The following is a description of a gene set: Genes up-regulated in the HSC supportive stromal cell lines. Human Gene Set: DURAND_STROMA_S_UP studied in species Mus musculus Stromal cell lines represent an exceptional tool to study the role on the microenvironment on hematopoietic stem cell (HSC) activity. We have compared the expression profile of HSC supportive vs non-supportive stromal lines generated from different hematopoietic tissues in the mouse, i.e the aorta-gonad-mesonephros (AGM) region, the fetal liver and the adult bone marrow, sequentially activated during development. In this study, six stromal lines were used with one HSC supportive and one non-supportive for each tissue (triplicate samples for each stromal line). We used Mouse Gene 1.0 ST microrrays in combination with GSEA and statistical analysis to identify lists of genes that segregate HSC supportive from non-supportive stromal lines., and this is the list of marker genes: PLXNA2, IL13RA1, TSPAN7, UBE2L6, PDK4, LRIG3, SLC37A2, PDLIM4, RGS4, FBLN1, PLXND1, SDC3, TRIM21, SRPX2, HOXC8, CRIP2, CTSO, LOXL1, RSPO2, ADAM19, CDKN1C, CSGALNACT1, NCKAP5, PCDHB15, CREB3L1, HCN2, PDGFRA (NCBI Gene Id 5156), MARCKS, CD248, UBASH3B, HYKK, SFRP2, UST, TEX15 (NCBI Gene Id 56154), ADAMTS2, ADGRL2, POPDC3, IVD, PXMP4, NPR2 (NCBI Gene Id 4882), TSC22D3, EBF3, RASSF2, EFNA5, SP8, PDGFRB, S100A16, COL6A2, MAP9, CLDN1, ARHGEF28, RTP4, OASL2P, FYB1, CCDC80, TGFBI, HOXB13, LGALSL, IGF1 (NCBI Gene Id 3479), CCL5, TFAP2A, PBXIP1, TMEM47, HSPB8, RHOBTB1, RBPMS2, POSTN, NDRG1, DOCK3 (dedicator of cytokinesis 3), ARRB1, PODXL, CFAP20DC, TBX20, CASTOR1, COL1A1, PDE1B, PLPP3, LPAR1, LPL, OXR1, GATA3, ST6GAL1, SLC43A1, CA13, MOGAT2, FAM20A, PRUNE2, SNAI2, LPAR4, IL4R, CCL7, SLC1A3, SERPINB1, SERPINB6, CIB2, NOVA1, DTX3L, PTX3, CCN5, CYP2J2, ADAM12, RNF150, PMP22, RALGAPA1, RPS6KA6, IL18RAP, CASP12, SEMA3F, GALNT13, DEPDC7, ZC2HC1A, FABP4, NES, TMEM121, CAPN6, INPP4B, FGFR2, RORB, PDE4D, IL1RL1, AOC3, GPER1, SOX5, COL3A1, C3orf33, PLEKHG4, CDYL2 (chromodomain Y like 2), KIRREL3, TVP23A, MRGPRF, NXF3, IL15, COL4A6, PPP1R13B, ALPL, SPEG, GAS2, MYO1D, NID2, ADAM8, GRIA3, HTRA3, ELL2, SLC27A3, PRRG1, AKAP6, DPYSL3, FZD1, STAT1, MTSS2, MEDAG, NPR3, CA5B, A4GALT, MID2, FGF10, ZNF618, IL1R1 (NCBI Gene Id 3554), PLAGL1, DCLK2, LRP11, NADK2, EHD3, NUDT14 (nudix hydrolase 14), CDK18, NDRG2, PAPPA, LTBP2, SMOC2, BACH2, B3GALNT1 (beta-1,3-N-acetylgalactosaminyltransferase 1 (Globoside blood group)), LHX9, PDE1A, ITGB3BP, THSD7A, CHST1, NCK2, IFI27, TMEM117, PLPP1, NRBP2, AHR, DYNC2I1, EPN3, SLFN13, ADAMTS12 (ADAM metallopeptidase with thrombospondin type 1 motif 12), RB1CC1, PALM2AKAP2, SIX1, LONRF3, KCNA4, INF2 (NCBI Gene Id 84800), MN1, ZNF518A, CRABP1, GLRX, PMVK, ELFN1, GSTT3P, MMP15, ARHGAP28, ZNF639, BTBD2, COL1A2, SYN1, PLEKHA2, AGO4, RAC3, MAGED2, TMEFF2, NCAM1, NFATC1, PTPRF, ST3GAL1, ANGPTL4, JAK3, EMB, TRAM1L1, SCN1B, SLC39A8, ARHGEF6, NOTCH4, SULF2, TCF7L1, BMPER, OASL, CDKN2B, CYP26B1, NYNRIN, PRKAR1B, NIBAN1, DUOXA1, FZD8, SPP1, ZDHHC2, FUT8, LRRC4C, KBTBD7, SVEP1, ANGEL1 (angel homolog 1), CABLES1, CXCL12, LAMTOR4, FAM110B, LGMN, JUP (NCBI Gene Id 3728), HLA-DMA, ZDHHC15, SPON2, PTN, EYA4, PORCN, PYGO1, EN1, DYNAP, SORCS2, EDA, SELP, MEST, SLC4A4, PRKD1, ONECUT2, FABP7, MMP2, RAB3IL1, GNAO1, TAF9B, ROR2, B4GALNT1, WNT10B, CORO2A, MORC4, FAT4, CEP170B, TSPAN6, CTSH, KITLG, ARC (NCBI Gene Id 53837), ATP10A, MAF (MAF bZIP transcription factor), ITM2A, PEAR1, PXYLP1, OSMR, IFIT1B, ADCY3, PHOSPHO1, DHRS7, SERPINF1, PAX9, SELENOP, RTN4RL1, MMP23B, CHST2, CALCRL (calcitonin receptor like receptor), ST6GALNAC2 (NCBI Gene Id 6488), MATN2, RTKN2, EIF4E3, S1PR1 (NCBI Gene Id 51546)